The following is a description of a gene set: Human Gene Set: GSE14699_NAIVE_VS_ACT_CD8_TCELL_UP Genes up-regulated in CD8 T cells: naïve versus activated. Peripheral tolerance induction is critical for the maintenance of self-tolerance and can be mediated by immunoregulatory T cells or by direct induction of T cell anergy or deletion. While the molecular processes underlying anergy have been extensively studied, little is known about the molecular basis for peripheral T cell deletion. Here, we determined the gene expression signature of peripheral CD8+ T cells undergoing deletional tolerance, relative to those undergoing immunogenic priming or lymphopenia-induced proliferation. From these data, we report the first detailed molecular signature of cells undergoing deletion. Consistent with defective cytolysis, these cells exhibited deficiencies in granzyme up-regulation. Furthermore, they showed antigen-driven Bcl-2 down-regulation and early up-regulation of the pro-apoptotic protein Bim, consistent with the requirement of this BH3-only protein for peripheral T cell deletion. Bim up-regulation was paralleled by defective IL-7Ra chain re-expression, suggesting that Bim-dependent death may be triggered by loss of IL-7/IL-7R signaling. Finally, we observed parallels in molecular signatures between deletion and anergy suggesting that these tolerance pathways may not be as molecularly distinct as previously surmised. from publication Parish IA, Rao S, Smyth GK, Juelich T, Denyer GS, Davey GM, Strasser A, Heath WR (PMID 19204323) species: Homo sapiens, and this is the list of marker genes: NUCB2, RAD51B, CEBPA, P4HA1, ICOSLG, RSPH3 (radial spoke head 3), PGLYRP1, APOBR, TGM2, MATN2, EBI3, AKR1B10, EPCAM, S100A6, GRPEL2, ATP5MG, FBXW8, MIPEP, TBC1D5, RPP40, RNF34, ACTN2, TMBIM1, CYB5B, CD160, HMGN3, C19orf44, HOPX, HACD3, H2AZ1, PON3, YBX3, RCN1, DNAH7, RWDD2A, WDR41, NDUFC1, CHST15, CD79B, PEAR1, IMMP2L, PLPP1, GJB2, RAPSN, ACSBG1, ST14, DECR1, RRAGD, WEE1, NTAQ1, LBH, SERPINC1, NIBAN1, METTL1, RPL36A, GABARAPL1, RAB3GAP2, PSMA2, CNKSR3, ZC3H7B, S100A4, ODC1, PDE2A, BID, SERPINB9, ITGB8, IL2RB, ICAM4, TIAM1, CKLF, CD200R1, CXCR5 (C-X-C motif chemokine receptor 5), ARRDC4, TKTL1 (transketolase like 1), PACRGL, HK2 (NCBI Gene Id 3099), KLHL12, TTC39C, ORMDL2, CYB5A, MANSC1, GSTO1, SLC25A53, WFDC2, S100A10 (S100 calcium binding protein A10), SLC2A3, USP27X, UQCC6, FHIP1A, FAM156A, ACOT11, SWAP70, FSD2, NFKBIE (NCBI Gene Id 4794), BMP7, SLC7A10, LYRM9, RSAD1, NCF4, CXCR3, NDUFA4, EBPL, CLDN12, CCDC28A, KLRG1, PENK, DTD1, LYRM1, PLSCR1, ACER2, CGRRF1, ACOT7, PDCD1LG2, PVT1, RAD23B, RAPGEF5, MELK, STX11, TSPAN3, BTK, NCMAP, IL10RA, GEMIN8, TMEM216, TMEM256, ECI1, SUSD2, SDHD, NAAA, DUSP4, PLGRKT, PCDHA12, AVEN, PHLPP1, HLA-DOB, RGS2, ACTG2, CNPY2, TSPAN31, CAPN3, ALAD, LRRC8D, CSRP2, CST7, DUT, DDX3Y, SBDS, SLC45A4, SH3BGRL2, DBNDD2, SDC4, APIP, ALOX15B, SUPT7L, DNAJC12, TJP2, SYNPO, KDM2B, LRIG1, CREG1, ANGPTL4, SMIM8, PRELID2 (PRELI domain containing 2), IL10RB, POLR2K, AXL, VAV2, FRMD6, ENSG00000286190, ITGAE, C1QTNF12, KIF13A, MRPL24, SLC35F2, MAGOH, HSPE1, BTG2, CYP4V2, PSAT1, CCL5, RECK (NCBI Gene Id 8434), OSBPL3, ZNF623, GZMB, HACL1, PRNP, ETV5, FMO5, JDP2, PLCB3, PSMA6, ZCCHC18, CHDH, ALDOC, NRN1, CSF1, TMEM128, SLC35D1, ABHD4